The following is a description of a gene set: part of: Transcriptional Regulation by TP53 Protein stability and transcriptional activity of TP53 (p53) tumor suppressor are regulated by post-translational modifications that include ubiquitination, phosphorylation, acetylation, methylation, sumoylation and prolyl-isomerization. In addition to post-translational modifications, the activity of TP53 is also regulated by binding of transcription co-factors.<p>In unstressed cells, TP53 protein levels are low due to MDM2-mediated ubiquitination of TP53, which triggers proteasome-mediated degradation. In response to stress, TP53 undergoes stabilizing phosphorylation, mainly at serine residues S15 and S20. Several different kinases can phosphorylate TP53 at these sites, but the main S15 kinases are considered to be ATM and ATR, while the main S20 kinases are considered to be CHEK2 and CHEK1. Additional phosphorylation of TP53 at serine residue S46 promotes transcription of pro-apoptotic, rather than cell cycle arrest genes.<p>Acetylation mainly has a positive impact on transcriptional activity of TP53, while methylation can both positively and negatively regulate TP53.<p>Some posttranslational modifications regulate interaction of TP53 with transcriptional co-factors, some of which are themselves transcriptional targets of TP53.<p>For review of the complex network of TP53 regulation, please refer to Kruse and Gu 2009, and Meek and Anderson 2009. Reactome Pathway: Regulation of TP53 Activity species: Homo sapiens, and this is the list of marker genes: EHMT1, BRD7, PPP2CA, NOC2L, AURKA, MAPK11, MDM2, RAD50, MAP2K6, RFC4, BRD1, AURKB, CDKN2A, TAF1L, MRE11, TAF15, ZNF385A, RPA3, TAF13, TAF10, CCNA2, TP63, TBP, CHD3, PIP4P1, RPS27A, PDPK1, CHD4, AKT1, UBB, TAF9B, PRKAG1, PPP2R1A, CSNK2A2, GATAD2B, CDK2, MEAF6, UBC, ATRIP, BANP, SUPT16H, BLM, TAF1, PRKAB2 (NCBI Gene Id 5565), PIP4K2A, TAF7, TAF5, RPA2, TP53BP2, BRIP1, HIPK1, SETD9, SSRP1, PLK3, PPP2R5C, TP53INP1, PRKAG3, TOP3A, PPP1R13B, TAF4, PRR5, TP53, BRPF3, DAXX, PRMT5, HIPK2, PIP4K2C, RMI1, DYRK2 (dual specificity tyrosine phosphorylation regulated kinase 2), KAT6A, ING5, ATM, HDAC2 (histone deacetylase 2), BRCA1, BARD1, TAF12, CDK5R1, NBN, RICTOR, HDAC1, RAD9A, WRN, ATR, SGK1 (NCBI Gene Id 6446), RFC5, RHNO1, PRDM1, HUS1, TAF11, CSNK2A1, KMT5A, PPP1R13L, EXO1, RAD17, GATAD2A, TAF4B, PHF20, ING2, TAF9, PPP2CB, RAD1, TPX2, SMYD2, MTA2, RFC2, MDM4, RAD9B, PRKAA2, RBBP7, CSNK2B, CCNG1, RNF34, USP7, PIN1, JMY, MAPK14 (mitogen-activated protein kinase 14), TOPBP1, AKT2, RFC3, TAF7L, MAPKAPK5, AKT3, RBBP8, MLST8, RMI2, CDK5, PIP4K2B, UBA52, CDK1, TAF2, POU4F1, TP53RK, EHMT2, PRKAB1, PRKAG2, CCNA1, RBBP4, RFFL, PPP2R1B, L3MBTL1, DNA2, TAF6, KAT5, USP2, STK11, RPA1, CHEK1, TAF3, NUAK1 (NCBI Gene Id 9891), CHEK2, MAPKAP1, TTC5, EP300, MBD3, MTOR, TP73, BRPF1, PRKAA1, TAF8, PML, POU4F2